The following is a description of a gene set: Binds to and increases the activity of a protein serine/threonine kinase. Human Gene Set: GOMF_PROTEIN_SERINE_THREONINE_KINASE_ACTIVATOR_ACTIVITY studied in species Homo sapiens, and this is the list of marker genes: MOB1A, FAM20A, TAB1, BMP2, ATG13, SAMD15, PIM1, DBF4, CCND2, MNAT1, TCL1B, CCNT2, CCDC88A, TOPBP1, CAB39, BMP7, CAB39L, CCNB1, ACSL1, NBN, MLST8, MTCP1, CKS2, STRADA, CKS1B, GCN1, BMP4, SAV1, TGFB1, AXIN1, MOB1B, CCNT1, RICTOR, SPRY2, ETAA1, DDX3X, CALM3, DELE1, IQGAP1 (IQ motif containing GTPase activating protein 1), TPX2, DAB2IP, DAZAP2, DBF4B, CDK5R1, MSTN, STK3, FERMT2, MAP3K12, ALS2, IGF2, CCNK, CDK5R2, IRGM, CALM1, LTF (NCBI Gene Id 4057), MAP2K1, CCND3, TNKS1BP1, RAD50, PARP16, PARP6, MAP3K13, TCL1A, CD40LG, GDF10, GDF2, TAOK1, PARP8, ADIPOQ, RHEB, CCND1, SLC27A1, STK4, STRADB, CALM2, MAP2K2, TAOK2, MAPRE3